Given this list of marker genes ENPP1, ADPRM, PDE6A, PDE1C, PDE5A, PDE1A, PDE6C, PDE6B, PDE10A, PDE3A, PDE4C, PDE4A, PDE3B, PDE1B, PDE6G, PDE7B, PDE9A, PDE11A, CNP, PDE8A, PDE6H, PDE8B, PDE4D, PDE4B, PDE2A, PDE7A, here is a description of the gene set: Human Gene Set: GOMF_CYCLIC_NUCLEOTIDE_PHOSPHODIESTERASE_ACTIVITY Catalysis of the reaction: a nucleoside cyclic phosphate + H2O = a nucleoside phosphate. studied in species Homo sapiens